The following is a description of a gene set: Mouse Gene Set: WP_KIT_RECEPTOR_SIGNALING_PATHWAY Kit receptor signaling pathway studied in species Mus musculus, and this is the list of marker genes: Ptpru, Inpp5d (NCBI Gene Id 98312), Ep300 (NCBI Gene Id 328572), Pik3cg, Plcg1, Cblb, Sh3kbp1, Prkca, Src, Mitf, Fgr, Vav1, Kitl, Spred2, Lyn, Hras, Stap1, Tec (NCBI Gene Id 21682), Prkcb, Csf2rb, Matk, Ptpn11, Ptpn6, Akt1, Cish, Socs4, Kit, Dok1, Hck, Stat5b, Raf1, Mpdz, Mapk1, Sh2b2, Epor, Pik3r1, Cbl, Grb2, Rasa1 (RAS p21 protein activator 1), Tnfrsf10b, Fyn, Socs1, Plce1, Vav2, Sos1, Map2k1, Bad, Yes1, Abl1, Grb10, Pik3r2, Stat5a, Cltc, Grap, Spred1, Socs5, Stat1, Fes, Btk, Rps6ka1, Jak2, Grb7, Crkl, Crk, Shc1 (NCBI Gene Id 20416), Socs6, Stat3